The following is a description of a gene set: species: Homo sapiens from publication Chen Y, Wang X (PMID 31504780) Human Gene Set: MIR5001_3P Genes predicted to be targets of miRBase v22 microRNA hsa-miR-5001-3p in miRDB v6.0 with MirTarget v4 prediction scores > 80 (high confidence targets)., and this is the list of marker genes: CHST6, ZNF559-ZNF177, GATAD2A, CHST2, TUSC3, GTF2E1, FMN1, ZBTB1, SLC39A6, SLC25A26, LMOD3, DENND11, POC1B, ZNF609, GTDC1, HAPLN1, SEZ6L, VCPIP1, SH2B3, OLIG1, RAPGEF5, ZFHX3, MOAP1, RAPGEF1, LMBR1, CABP7, CNTLN, GPAT3, NRG4, MAGEA5P, TXLNB, ENTREP1, C1orf216, RNASE11, NCOR2, UCHL5, PLCB4, USP51, TLE4, SORCS1, RAB37, CD164, TPPP, TAF7, TNIK, SRPRA, CDY1B, PAFAH1B1, BPTF, ZKSCAN8, PALLD, ABHD4, ZNF132, POLH, IL1F10, UQCR10, C1orf141, PYGO2, CTC1, SSR1, THSD7B, CLINT1, VPS35L, ZFC3H1, TPBGL, STK3, MACF1, FUT9, GPR176, USP34, USP48, SH3PXD2B (SH3 and PX domains 2B), TMEM53, TNFRSF13B, ENSG00000266560, NHLRC2, CARF, TMEM178B, CDY1, NR4A3, NIPBL, GNAL, PTBP2, EDAR, EML4, NFIB, SUMF2, PLB1, PROS1, PCSK5, AFF2, FAS, AAK1, PDCD2 (NCBI Gene Id 5134), ANOS1, IREB2, SLC25A36, RPA1, PKNOX2, RDH10 (NCBI Gene Id 157506), BMPR1A, AIMP1 (NCBI Gene Id 9255), MPZL1, GREM2, TP53RK, COLEC10, DENND1B, ADAMTS5, RAB3B, GSPT1, EI24, ATRX, CFAP263, TBCEL, GATA3, LPP, SCAI, GRID2 (NCBI Gene Id 2895, glutamate ionotropic receptor delta type subunit 2), GID4, NLGN1, TIA1, GABPA, STRAP, JPT2, PSMC2, NF2, NAV3, ENPEP, PTN, TRAM2, SLC6A11, ZNF215, METTL21A, DCAF5, NCOA1, PRKAB2, PROM2, BACE1, CERS3, NFAT5, RCC1L, DDX3X, ZFAND5, NFATC2, NR4A2, RASSF5, CSTF3, SIRT5, FAM32A, MRPL17, CA12, ODC1, ANKRD7, RBM39, DGKG, FIRRM